Given this list of marker genes CTBP1, FGFRL1, LETM1, NSD2 (NCBI Gene Id 7468), CPLX1, MAF, here is a description of the gene set: Craniofacial asymmetry Human Gene Set: HP_CRANIOFACIAL_ASYMMETRY Asymmetry of the bones of the skull and the face. species: Homo sapiens